The following is a description of a gene set: Human Gene Set: GSE12392_WT_VS_IFNAR_KO_CD8A_NEG_SPLEEN_DC_UP studied in species Homo sapiens Type I Interferons encompasses a large family of closely related cytokines comprising of at least 13 IFN-α isotypes and single IFN-β. Both IFN-α and IFN-β exert their activity through a common receptor IFNAR. Type I Interferons have broad regulatory effects and various subtypes of dendritic cells are influenced by this cytokines. In our study we asked question whether the low, constitutive levels of type I Interferons produced under steady state conditions are important for proper function of splenic conventional dendritic cells. from publication Zietara N, Łyszkiewicz M, Gekara N, Puchałka J, Dos Santos VA, Hunt CR, Pandita TK, Lienenklaus S, Weiss S (PMID 19581626) Genes up-regulated in CD8A- splenic dendritic cells: wildtype versus IFNAR1 knockout mice., and this is the list of marker genes: ARRB2, FRRS1, CASS4, RPS6KA4, STXBP2, CASP1, ADAMTS10, CEBPD, IFI30, CDC42EP3, USP6NL, ANXA3, MYO1H, SLC44A1, TRIM37, BCL2L12, ABCB1 (NCBI Gene Id 5243), ST14, RGL1, STARD9, CARD6, CRLF3, NDST1, PGLYRP2, LYSMD2, KPTN, NHERF1, ZNF658, SPN, HPGDS, MREG, LYST (NCBI Gene Id 1130), SNX9, MAN2A2, CFLAR, SLC6A12, RUNX3, TAGAP, REM1, BASP1, ELMO1, PAOX, GLDC, STAG3, SMIM5, TESC, PRKCB, SASH1, RTN1, SETX, TNFRSF13B (NCBI Gene Id 23495), OTULINL, HCK, CYFIP1 (cytoplasmic FMR1 interacting protein 1), MICAL1, ESAM, ADGRG6, LRP8, CTC1, SEMA4B (NCBI Gene Id 56962), DAPP1, ABHD6, RNF111, RHOF, PDCD4, WRAP73, RRAS2, SBSN, B4GALT1 (NCBI Gene Id 2683), CDC42EP2, HPF1, SDC4, FBRSL1, PLEKHA1, STARD7, IL6ST, MYO9B, NOD1, UPF2, APP, SIGLEC7, SLC29A1, EYA1, UBAC2, TESK2, PURG, SMAD7, SEMA4D, SYK, DENND5A, CCRL2, SNORD89, AEBP2, PRDX6, CARMIL1, RPS6KA3, CD300A, SWAP70, IPO7, ICOSLG, GCNT1, AP3M2, KLHL25, RABGAP1, RUNDC3B, PEX16, DEPDC1B (DEP domain containing 1B), LRRK1, SASH3, EEF2K, RECQL5, MAP3K14, PGGHG, IGLC7, IKZF1, TCF4, CPSF4, NXPE3, IL21R, NCOA3, AP1S2, SOCS2, SMIM3, ARHGAP39, CLEC7A, SCNN1G, IL4I1, TMEM71, SAT1 (NCBI Gene Id 6303), STK24, SESN1, NELFB, CASP4, SYNGR2, CCDC88C, IFITM2, CYRIA, PPP1R3B, BIRC2, NFKBIE, PILRA, KRT80, JAK2, ARAP2, STARD5, ARHGAP6, RNF114, DONSON, NHSL2, XPNPEP1, PNKP, ISL1, CD5, PLEKHG2 (pleckstrin homology and RhoGEF domain containing G2), PECAM1, IGSF6, TMEM131L, PTPN6, IFIT3, ARRDC2, CTSD, STIMATE, SLFN12L, CARD11, LPP-AS2, UBE2E2, RARG, RUNX2, PMS2, POLB, TOX2, CAMKMT, BRPF3, SLC12A2, RAP1GAP2, MTMR3, SIGLEC10, GPRC5B, SPECC1, PLXND1 (plexin D1), ITGA4, TBC1D10C, PANX1, LRP1, MAPK14, FLVCR1, TMEM170B, RMND5B, CRLF2, DMAC2, NCALD, TMEM273, STING1, OAS1, DGKA, MYO1E, NPC1, YPEL3, SULF2, HMG20A